Given this list of marker genes EP300, ATF4, IVL, CXCL8, SP1, CCND1, FOSL2, DMTF1, GJA1, CCNA2, CCL2, PLAU, MMP1, BGLAP, NOS3, CDKN2A, IL6, NFATC1, NFATC3, PLAUR, ITGB4, USF2, HMOX1, THBD, LAMA3, MMP2, TXLNG, FOSL1, LIF, NFATC2, JUND, COL1A2, JUNB, MGP, MMP9, DCN, JUN, here is a description of the gene set: Validated transcriptional targets of AP1 family members Fra1 and Fra2 from publication Schaefer CF, Anthony K, Krupa S, Buchoff J, Day M, Hannay T, Buetow KH (PMID 18832364) Human Gene Set: PID_FRA_PATHWAY species: Homo sapiens